The following is a description of a gene set: Human Gene Set: HP_ABNORMAL_CORTICOSPINAL_TRACT_MORPHOLOGY species: Homo sapiens Abnormal corticospinal tract morphology Abnormality of the corticospinal tract, which is the chief element of the pyramidal system (the principle motor tract) and is the only direct connection between the cerebrum and the spinal cord., and this is the list of marker genes: PDHB, LIMK1, VPS37D, PRPH, WASHC5 (WASH complex subunit 5), PLP1, TBK1, BAZ1B, DCTN1, SLC33A1, KPNA3, GTF2IRD2 (GTF2I repeat domain containing 2), SPG11, EIF4H, ABCD1, VCP, BUD23, SPG7, GALC, TMEM270, RAD51, ELN, ALS2, SPAST, CHCHD10, NIPA1, NTN1, DCC, STX1A, FUS, TARDBP, NEFH, NCF1, DNAL4, UBAP1, RTN2, SOD1, CLIP2, CPT1C, DNAJC30, L1CAM, FKBP6, ATL1, TBL2, METTL27 (methyltransferase like 27), MT-ATP6, GTF2IRD1, GTF2I, SQSTM1, RFC2